Given this list of marker genes Etfbkmt, Dnajb3, Ppef2, Cdk5r1, Hnrnpk, Snca (synuclein, alpha), Limk1, Hspa1b, Cdc37l1, Arhgdia, Spn, Eef1d, Tsacc, Fkbp4, Dnajc18, Hspa13, Cyp27a1, Hspa1a, Usp19, Rps3, Nfkbia, Dmp1, Dnaja4, Dnajb2, Fkbp1a, Fkbp5 (FK506 binding protein 5), Hif1a, Dnajb6, Ptges3-ps, Pttg1, Prkn, Hsf1, Fgf1, Erbb2, Bcor, Hspa9, St13, Eno1, Itgam, Ppid, Atf5, Ppp5c, Hspa1l, Dnajc6, Dnajc9, Dnajb8 (DnaJ heat shock protein family (Hsp40) member B8), Ksr1, Dnaja3, Rnf207, Hspa5, Nod2, Ptges3, Itgb2 (NCBI Gene Id 16414), Pglyrp1, Npas2, Cdc37, Ern1, Creb1, Mapt, Prkd1, Tpr, Cdk1, Mettl22, Pacrg, Fkbp6, Eif2ak3, Stau2, Bak1, Tomm34, Chordc1, Mettl21a, Ssu2, Sgtb, Hdac6, Iqcg, Itgb2l (integrin beta 2-like), Unc45a, Hspa14, Nos2, Gucy1b1, Ogdh (NCBI Gene Id 75674), Tfam, Lman2, Cyp1a1, Dlst, Slc18a2, Ago2, Zfp36, Dnaja2, Dnajc10, Bag6, Bmal1, Apaf1, Cdkn1b, Hsp90ab1, Unc45b, Cyp2e1, Hspa8, Mvd, Cltc, Slc12a2, Gpr37, Eef1akmt3, Faf1, Eno1b, Hdac2, Dnajb14, Hspa2, Hdac8, Hikeshi, Tfrc, Tsc2, Dnajb7, Camkmt, Nup62, Bax, Irak1, Ahr, Apoa1, Dnajc7, Nos3, Sacs, Telo2, Nr3c1, Dnaja1, Ficd, Dnajb9, Dnajb12, Mettl18, Ahsa1, Gmeb1, Tsc1 (TSC complex subunit 1), Bag2 (BCL2-associated athanogene 2), Dnajc2, Dnajb1, Stub1, Cyp2b10, Mettl21c, Kcnj11, Stip1, Pdxp, Ttc4, Kpnb1, Mettl23, Adora1, Nfkb1, Ulk1, Gbp2, Ptges3l, Dnajc8, Cdk5, Apoa2, Cd24a, Gbp2b, Htt, here is a description of the gene set: Binding to a heat shock protein, a protein synthesized or activated in response to heat shock. studied in species Mus musculus Mouse Gene Set: GOMF_HEAT_SHOCK_PROTEIN_BINDING